The following is a description of a gene set: studied in species Homo sapiens from publication Mellman DL, Gonzales ML, Song C, Barlow CA, Wang P, Kendziorski C, Anderson RA (PMID 18288197) Human Gene Set: MELLMAN_TUT1_TARGETS_UP Phosphoinositides are a family of lipid signalling molecules that regulate many cellular functions in eukaryotes. Phosphatidylinositol-4,5-bisphosphate (PtdIns4,5P2), the central component in the phosphoinositide signalling circuitry, is generated primarily by type I phosphatidylinositol 4-phosphate 5-kinases (PIPKIalpha, PIPKIbeta and PIPKIgamma). In addition to functions in the cytosol, phosphoinositides are present in the nucleus, where they modulate several functions; however, the mechanism by which they directly regulate nuclear functions remains unknown. PIPKIs regulate cellular functions through interactions with protein partners, often PtdIns4,5P2 effectors, that target PIPKIs to discrete subcellular compartments, resulting in the spatial and temporal generation of PtdIns4,5P2 required for the regulation of specific signalling pathways. Therefore, to determine roles for nuclear PtdIns4,5P2 we set out to identify proteins that interacted with the nuclear PIPK, PIPKIalpha. Here we show that PIPKIalpha co-localizes at nuclear speckles and interacts with a newly identified non-canonical poly(A) polymerase, which we have termed Star-PAP (nuclear speckle targeted PIPKIalpha regulated-poly(A) polymerase) and that the activity of Star-PAP can be specifically regulated by PtdIns4,5P2. Star-PAP and PIPKIalpha function together in a complex to control the expression of select mRNAs, including the transcript encoding the key cytoprotective enzyme haem oxygenase-1 (refs 8, 9) and other oxidative stress response genes by regulating the 3'-end formation of their mRNAs. Taken together, the data demonstrate a model by which phosphoinositide signalling works in tandem with complement pathways to regulate the activity of Star-PAP and the subsequent biosynthesis of its target mRNA. The results reveal a mechanism for the integration of nuclear phosphoinositide signals and a method for regulating gene expression. Genes up-regulated in HEK293 cells (embryo kidney) after knockdown of TUT1 by RNAi., and this is the list of marker genes: RPL31, SLU7, SF3B6, DDX52, TXNDC2, ATF6, LARP1, MTHFD2, PTBP1, SF3A2, MTHFD2L, CSNK2A1, SNX17, G6PD, RPL23, SNX13, TKT, NDUFV3, SDR42E1, PAPOLG